The following is a description of a gene set: The directed movement of tRNA, transfer ribonucleic acid, into, out of or within a cell, or between cells, by means of some agent such as a transporter or pore. studied in species Mus musculus Mouse Gene Set: GOBP_TRNA_TRANSPORT, and this is the list of marker genes: Ssb, Xpot, Tomm20l, Ybx1, Nol6, Tomm20